The following is a description of a gene set: species: Homo sapiens from publication Busslinger GA, Weusten BLA, Bogte A, Begthel H, Brosens LAA, Clevers H (PMID 33691112) Human Gene Set: BUSSLINGER_DUODENAL_TRANSIT_AMPLIFYING_CELLS, and this is the list of marker genes: LGALS4, ATP5PB, COX5B, CCL25, PTGES3, PTMA, EI24, NCL, RPS19, RPS9, CDC42EP5, EEF2, RPL14, RPS8, TXN, TFRC, HSPD1, RPS4X (ribosomal protein S4 X-linked), EEF1A1 (eukaryotic translation elongation factor 1 alpha 1), RPL34, PPP1R1B, KRT19, ATP5F1A, RPS16, EEF1G, RPL35A, RPL5, RPL6, RPL11, PHB1, RPL19, EEF1B2, RAN, RPL7, RPL37, DDAH1, PSME2, MAOA, RPL18A (ribosomal protein L18a), TPI1, RPL24, EIF3L, ATP5MC1, RPL35, RPL7A, ATP5MJ, RPS2 (NCBI Gene Id 6187), ATP5IF1, RPS14, RPS6, RPL36, MT2A, RPS15, NDUFA1, TM9SF3, ATP5MC2, IER2, ACTG1, ADD3, RPL37A, RPL32, SLC25A5, NPM1, RPL9, RPL29, H2AZ1, COX7C, RPL39, HSPE1, PFN1, NDUFB9, RACK1, RPL13A, NDUFAB1, PHB2, RPL28, RPS3, RPS5, CHCHD2, RPS15A (ribosomal protein S15a), TMSB10, RPL22, RPL17, EPCAM, CENPF, RPL8, RPLP0, RPL18, REG1A, GOLM1, CYCS, EIF3K, KRT18, ARL6IP1, RPLP2, SNHG29, ALDH1A1, RPS24, RPL10, SF3B5, KLF5, RPS23, UQCRFS1, RPL27, ANP32B, RPL10A, RPL27A, COX6B1, TUBA1B, COX5A, AGR2, RPS3A, RPS25, RPL15, RPL4, HINT1 (NCBI Gene Id 3094), NDUFS5, RPS20 (NCBI Gene Id 6224), COX7B, RPS11, RPL12, ESD, RPL41, HSP90B1, RPS28, YBX1, CHCHD10, ATP5PO (NCBI Gene Id 539), ALDOA, DBI, RPS18, MGST1, RPS7, ATP5PD, RPS27A, COX4I1, ATP5F1B, RPLP1, COX7A2, RPL26, COX8A, ATP5MF, PPIA, RPS12, CLIC1, RBM3, CANX, TUFM, HNRNPA1, IDH2, FBL, RPL3 (ribosomal protein L3), HSP90AB1, H4C3, HNRNPA2B1, UQCRQ, SLC25A3, FAU, NUCKS1, CHP2, ATP5F1C, GAPDH, ATP5MG, PSMA5, ATP5MC3, RPL13, MKI67, TOP2A, ECH1, PIGR, CPS1, MLEC, RPS29, KRT8, ADH1C (NCBI Gene Id 126), AKR1C3, UQCR10, MARCKS, COX6C, MT1G, DMBT1, ATP5ME, COX6A1, HMGB1, HMGB2, GSTP1, PRDX1, CYC1, RPL38, ENO1, RPL23, RPS13, HMGA1, HNRNPC